The following is a description of a gene set: studied in species Homo sapiens Human Gene Set: HP_FASTING_HYPOGLYCEMIA Fasting hypoglycemia, and this is the list of marker genes: HNF4A, INSR, GCDH (glutaryl-CoA dehydrogenase), SLC1A1, PHKA2 (NCBI Gene Id 5256), FBP1, ABCC8, SLC2A2, IGF2, HNF1A, SLC25A20, IARS2, GRB10, AKT2, GYS2, PCK1, G6PC1, PHKG2, TBX19 (NCBI Gene Id 9095), PHKB, KCNJ11, SECISBP2